Given this list of marker genes TTC21A, ALG5, OFD1, TTC12, DZIP1, CATSPER2, DNAAF1, DNAAF3, MCIDAS, RSPH3, HYDIN, SEPTIN12, CCDC34, CYLC1, CATSPER1, DNAAF6, SLC26A8, USP26, WDR19, DNAI2, DNAH9, DNAH10, ODAD2, GANAB, ALG9, DNAH7, DNAH5, CFAP74, CCDC146, DNAAF4, LRRC56, DNAH11, DNAH2, ZMYND10, SPAG1, ARMC12, PDE11A, GAS2L2, AKAP3, PKD2, CT55, RSPH9, BRDT, SPAG17, CATIP, CFAP61, BRWD1, CFAP65, NEK10 (NCBI Gene Id 375328), ODAD3, PDHA2, CFAP300, HNF1B, PKD1, CFAP47, CCIN, DNAAF2, RPL10L, NME5, RPGR, SPEF2, CFAP43, ARL2BP, ODAD4, GBA2, AK7, STK36, FBXO43, SPINK2, DNAJB13, DNAL1, DNAAF11, DNAH17, CEP112, CFAP251, CDC14A, SUN5, CFAP58, IFT74, DRC1, PMFBP1, CCDC40, CCNO, TTC29, KLHL10, CFAP221, ODAD1, DNHD1, SPACA1, FOXJ1 (forkhead box J1), DNAH1, KCNU1, DNAI1, CFAP45, DNAAF5, PRKAR1A, CFAP410 (cilia and flagella associated protein 410), RSPH1, ARMC2, STK33, TEKT3, CFAP70, SSX1, CFAP69, DNALI1, DNAJB11, DNAH8, FSIP2 (NCBI Gene Id 401024), NME8, BICC1 (NCBI Gene Id 80114), CCDC39, RSPH4A, STRC, CFAP91, CFAP298, LRRC23, IFT140, here is a description of the gene set: Abnormal sperm physiology species: Homo sapiens Human Gene Set: HP_ABNORMAL_SPERM_PHYSIOLOGY Abnormality of a sperm function including protection of paternal DNA, traversing the female reproductive tract, oocyte localisation, penetration of the zona pellucida, oocyte activation and centriole deposition.